Given this list of marker genes Slc7a8, Slc22a2, Slc17a3, Slc29a4, Slc22a3, Slc22a1, Slc22a19, Abcg1, Abcc2, Lrp6, here is a description of the gene set: Enables the transfer of a toxin from one side of a membrane to the other. A toxin is a poisonous compound (typically a protein) that is produced by cells or organisms and that can cause disease when introduced into the body or tissues of an organism. Mouse Gene Set: GOMF_TOXIN_TRANSMEMBRANE_TRANSPORTER_ACTIVITY species: Mus musculus